Given this list of marker genes Ice2, Inhba, Tenm1, Myo1c, Setd5, Chd8, Dhx36, Ercc6, Brf1 (NCBI Gene Id 72308), Mtor, Mybbp1a, Baz1b, Rptor, Zc3h8, Ice1, Dek, Brf2, Smarca5, Ell, Ddx21, Sf3b1, Ar, Maf1, Foxa2, Prdx5, Nab2, Ski, here is a description of the gene set: Any process that modulates the frequency, rate or extent of transcription mediated by RNA ploymerase III. Mouse Gene Set: GOBP_REGULATION_OF_TRANSCRIPTION_BY_RNA_POLYMERASE_III species: Mus musculus